The following is a description of a gene set: Cytokines mediate cell-cell communication in the immune system and represent important therapeutic targets. A myriad of studies have highlighted their central role in immune function, yet we lack a global view of the cellular responses of each immune cell type to each cytokine. To address this gap, the authors created the Immune Dictionary, a compendium of single-cell transcriptomic profiles of more than 17 immune cell types in response to each of 86 cytokines (>1,400 cytokine-cell type combinations) in mouse lymph nodes in vivo. A cytokine-centric view of the dictionary revealed that most cytokines induce highly cell-type-specific responses. For example, the inflammatory cytokine interleukin-1β induces distinct gene programmes in almost every cell type. A cell-type-centric view of the dictionary identified more than 66 cytokine-driven cellular polarization states across immune cell types, including previously uncharacterized states such as an interleukin-18-induced polyfunctional natural killer cell state. studied in species Mus musculus Genes positively differentially expressed in cell type: eTAC (extrathymic Aire-expressing cell) upon treatment with cytokine: IL-1α in mouse lymph nodes in vivo. from publication Cui A, Huang T, Li S, Ma A, Pérez JL, Sander C, Keskin DB, Wu CJ, Fraenkel E, Hacohen N (PMID 38057668) Mouse Gene Set: CUI_ETAC_IL1A_RESPONSE_UP, and this is the list of marker genes: Ccl17, Mdn1, Pla1a, Stat5a, Il4i1